Given this list of marker genes IL6, AHR, VEGFA, PTGS2, CYP1A1, IL22 (NCBI Gene Id 57328), CYP1B1, ARNT, here is a description of the gene set: Human Gene Set: KEGG_MEDICUS_REFERENCE_AHR_SIGNALING_PATHWAY AhR signaling pathway. Pathway ID: N00317. Pathway type: Reference. Pathway class: nt06227 Nuclear receptor signaling. studied in species Homo sapiens Pathway Definition from KEGG: KA -> (AHR+ARNT) => (IL6,IL22,PTGS2,VEGFA,CYP1A1,CYP1B1)